Given this list of marker genes SYNGR4, HCRTR1, GABRB2, RBM47, BGN, HOXB1, P4HA2, SMURF2, HBEGF, TRIM52, ZNF710, IL37, WDR45B (NCBI Gene Id 56270), GRAMD4, WNT11, PGM5, H6PD, SNX17, ARHGAP26, SIT1, CPE, PRMT2, VPREB3, SPMAP2, TEX11, CD40LG, PPP3CA, KIAA0753, GADD45B, NOL4, SSH1, ERC2-IT1, CHKA, ATAD2B, CLDN15, BRMS1, LOXL2, ZBED2, EIF4G3, TMX4, PLEKHO1, DYRK3, PSTPIP1, ASMTL, LRRC20, POLL, GDF11, TNFRSF1A, SOCS5, SMOX, CD59, MICALL2, ANKRD40, CYP1A1, TRAT1, H2BC8, OPCML, H2BC10, TUFT1 (NCBI Gene Id 7286), CLEC3B, FHL3 (four and a half LIM domains 3), BCL7C (NCBI Gene Id 9274), PON3, OMD, UGT2B17, AKAP17A, CDC42EP2, MYCNOS, FZD8, HSD17B4, ATP6V0D1, PTK7, IL12B, CDC27 (NCBI Gene Id 996), SMG6, HOXB5, PCID2, SEMA3C, CFLAR, NPHP4, PLEKHF1, GYG1, ZNF234, TRAF3IP1, SERPINB13, ANKRD40CL, ICAM1, BAIAP2L2, PLAUR, BIN1, GRTP1, ANKRD46, ADRB3, IVNS1ABP, SMC5, TLK2, GVINP1, NSMF, SMAD4, RAG1, ABI2, ADAM12, RAPGEF6, PHLDA2, PPARD, CCR1, SLC39A1, NUP43, ITIH1, SETMAR, TMEM38B, IFNA14, PHF3, LMCD1, TMEM186, POU3F1, MAN1B1, MEAF6, CYP11B1, HEXIM1, FAM32A, PELO, ANP32CP, CREB3, ATP10D, CFHR4, IL12RB1, MAPK12, TGM5, SYTL2, GLS, PTK6, ETV5, SS18L1, MC1R (melanocortin 1 receptor), H2AC6, MAP3K6, CCZ1B, TIPRL, SYNJ1, GPATCH3, SBF1, RHOF, DCAF15, SMG9, GPR27 (G protein-coupled receptor 27), TLN1 (NCBI Gene Id 7094), SLC17A2, ARF3, KRT1, DNAJC28, HMGCS2, KLRG1, MDFIC, FABP4, PRDM13, TGFBR2, FEZ1, RAB5B, AOAH, PPP6R3, ACSBG2, CENPQ, CCL20, FKBP11, C1orf159 (NCBI Gene Id 54991), HUS1, ELMO2, CTNNA1, TRAPPC2, TSPAN14, CTNND1, MAPK13, ATP8B4, RAB17, IL21, SERPINF1, HBS1L, HIF1AN, TGIF1, PRR5, CA3, UEVLD, PML, CACNA2D3, PRKCH, CENPS, PSMD3, TNNC1 (NCBI Gene Id 7134), PTP4A2, PGAP4, SERPINA2, CLDN9, BCKDHB, COL18A1, EEF1AKMT3, RANBP3 (NCBI Gene Id 8498), NEDD4L, here is a description of the gene set: studied in species Homo sapiens Genes up-regulated in hematopoietic stem cells versus pro-B cells. Human Gene Set: GSE37301_HEMATOPOIETIC_STEM_CELL_VS_PRO_BCELL_UP Expression profiling of Rag2-deficient Ets1++ and Rag2-deficient Ets1-- mature NK cells and WT bone marrow progenitors, WT T cells, and WT Pro B cells from publication Ramirez K, Chandler KJ, Spaulding C, Zandi S, Sigvardsson M, Graves BJ, Kee BL (PMID 22608498)